Given this list of marker genes HPX, LTA, TREM2, TNF, PTPRC, FCER2, here is a description of the gene set: species: Homo sapiens Human Gene Set: GOBP_POSITIVE_REGULATION_OF_HUMORAL_IMMUNE_RESPONSE_MEDIATED_BY_CIRCULATING_IMMUNOGLOBULIN Any process that activates or increases the frequency, rate, or extent of a humoral immune response mediated by circulating immunoglobulin.